Given this list of marker genes Mzt2 (mitotic spindle organizing protein 2), Tubgcp5, Tubgcp6, Mzt1, Cdk5rap2, Tubg1, Nme7, Tubg2, Nedd1, here is a description of the gene set: species: Mus musculus A complex of gamma tubulin and associated proteins thought to be formed by multimerization of gamma-tubulin small complexes. An example of this structure is found in Schizosaccharomyces pombe. Mouse Gene Set: GOCC_GAMMA_TUBULIN_RING_COMPLEX